The following is a description of a gene set: Human Gene Set: HP_CEREBRAL_HYPOPLASIA species: Homo sapiens Cerebral hypoplasia Underdevelopment of the cerebrum., and this is the list of marker genes: STIL, NUP37, SARS1, ANKLE2, FIG4, WDR45B, CEP135, HSD17B4, GCDH, TAF13, CNNM2, FOXG1, MCM7, KIAA0586, MBD5, HHAT, PYCR2, TRAPPC10, KIF14, COASY, ASPM, VAC14, RNU4ATAC, ATP1A1, SLC35C1, SASS6, KNL1, PHGDH, WDR62, CEP63, CDK6, PHC1, MKS1, COPB2, CEP152, CSPP1, BRAF, MCPH1, CENPE, RTTN, BUB1B, WARS1, DPM1, FDXR, DHCR7, MFSD2A, CDK5RAP2, CIT, FH, METTL5, C2CD3, TRAPPC14, NCAPD3, MYSM1, ARHGEF9